The following is a description of a gene set: Mouse Gene Set: GOBP_REGULATION_OF_GLUTAMINE_FAMILY_AMINO_ACID_METABOLIC_PROCESS studied in species Mus musculus Any process that modulates the frequency, rate or extent of the chemical reactions and pathways involving amino acids of the glutamine family, comprising arginine, glutamate, glutamine and proline., and this is the list of marker genes: Slc7a11, Atp2b4, Nr1h4 (nuclear receptor subfamily 1, group H, member 4), Cln3, Apc, Atcay, Sirt4